Given this list of marker genes Sec11a, Spcs1, Sec11c, Arxes1, Spcs3, Spcs2, Arxes2, here is a description of the gene set: A protein complex that is located in the endoplasmic reticulum membrane and cleaves the signal sequence from precursor proteins following their transport out of the cytoplasmic space. Mouse Gene Set: GOCC_SIGNAL_PEPTIDASE_COMPLEX studied in species Mus musculus